Given this list of marker genes EXOC4, PRKCZ, ITGB1 (NCBI Gene Id 3688), DLG1, SCRIB, here is a description of the gene set: Human Gene Set: GOCC_MYELIN_SHEATH_ABAXONAL_REGION species: Homo sapiens The region of the myelin sheath furthest from the axon.